The following is a description of a gene set: from publication Chen Y, Wang X (PMID 31504780) species: Homo sapiens Genes predicted to be targets of miRBase v22 microRNA hsa-miR-4524b-5p in miRDB v6.0 with MirTarget v4 prediction scores > 80 (high confidence targets). Human Gene Set: MIR4524B_5P, and this is the list of marker genes: CDK5R1, DMTF1, UBR3, CDC14A, PPP1R11, NSD2, GHR, KIF2A, CFAP45, CDC37L1, CMPK1, NHLRC2, VEGFA, VSX1, ARHGAP32, PPP2R5C, TMEM100, CAPZA2, RIMKLB, RREB1, CCDC6, PURG, DENND1B, AKT3, ZBTB44, RASGEF1B, SLC24A3, ZNF697, ATXN2, TMEM74B, PROX1, FGF2, FGF7, GOLGA1, DRAM1, SLC2A14, KLHL2, PNPLA6, UHMK1, AK4, SLC30A8, DCLK1, IFT74, PTCD3, OCRL (NCBI Gene Id 4952), LRRK1, PARD6B, PRDM4 (NCBI Gene Id 11108), TENM2, NPTN, STK33, AAK1, DESI1, NAA15, CACNA1E, MYRIP (myosin VIIA and Rab interacting protein), DNAJA2, SPRED1, PDZD8, SALL1, KCNN4, FCHSD2, PTPRR, EPHB2, EFCAB5, ZNRF3, CDK8, UNC80, TLK1, PAFAH1B1, GALNT13, CPEB2, PNRC2, CCNE1, CCND2, SRPRA, TOX3, SEL1L3, KCNQ5, DYNC1LI2, SEMA6D, ARMH4, CYP26B1 (cytochrome P450 family 26 subfamily B member 1), ISLR, MAPK8, KIF21A, TSPYL2, PABIR1, OMG, TMEM183A, SIRT4, SYDE2, ALDH1A3, MOB4, SMURF1, MYB, NFE2L1, HECTD1, ACSL4, STXBP5 (syntaxin binding protein 5), SLC12A2, CBX4, USP31, OOEP, TNRC6B (NCBI Gene Id 23112, trinucleotide repeat containing adaptor 6B), MPDZ, RFX3, CCNJ, RECK, UNC13A, GSTCD, CCND1, GPR63, CBFA2T3, MOV10, ZBTB46, YTHDC1, ZMAT3, BTRC, NRN1, SLC11A2, TNFSF13B, PAPPA, PTPRD, HMGA2, CCDC83, ZBTB39, ZFHX3, KCNJ2, CMC4, C1orf21, CHAC1, ANKS1A, RICTOR, BCAP29, CD2AP, UBE4B, ZNF622, TMEM245, MTAP, PTPN3, PPP2R1B, NDP, SREK1, C12orf76, ARL2, IKBKB, TMCC1, ZC3H13, EMC4, BTAF1, SEC24C, SESN1 (NCBI Gene Id 27244), MAP2K1, ORMDL1, SEC24A, GAREM1, RUNDC3B, ST8SIA3, USP12, ADAMTS3 (ADAM metallopeptidase with thrombospondin type 1 motif 3, NCBI Gene Id 9508), SLC2A3, PAM, GATA2, FRY, NOS1, CACUL1 (CDK2 associated cullin domain 1), SEMA3D, SMAD7, PLAG1, MED26, TBL1XR1, HECTD4, ACTR2, ATP7A, RNF144B, KIF5C, ACVR2A, RPS6KA6, WIPI2 (WD repeat domain, phosphoinositide interacting 2), GNAI3, CDHR1, MGAT4A, FAM81A, CYP2S1, KDSR, MOB3B, IPO7, ARHGAP20, TAOK1, CPEB3, GLCE, SMURF2, PACRG, UBN2, PLEKHA1, CDK17, ELL2, ZNF367, SLIT2, USP25, WEE1, SOCS6, PTPN4, CDC27, MAP3K7, GABRA2, SALL3, CDCA4, BMPR1A, LIMS3, HSPA8, ASH1L, QKI, NAV1, PIP4P2, PTH, CBX2, RAB11FIP2, DEPDC4, TMC7, SLC35G1, FBXW7, LIMS4, N4BP1, NUP50 (NCBI Gene Id 26132), G2E3, SLC20A2, CREBRF, EPHA7, UBQLNL, STOX2, VPS33B, ZFHX4 (zinc finger homeobox 4), KANK1, LAMP3, MEOX2, CREB5, SLC25A37, KIF23